The following is a description of a gene set: Genes down-regulated in CD4 T conv over-expressing: GATA1 and SATB1 versus control. from publication Fu W, Ergun A, Lu T, Hill JA, Haxhinasto S, Fassett MS, Gazit R, Adoro S, Glimcher L, Chan S, Kastner P, Rossi D, Collins JJ, Mathis D, Benoist C (PMID 22961053) The transcription factor FoxP3 partakes dominantly in the specification and function of FoxP3+ CD4+ T regulatory cells (Tregs), but is neither strictly necessary nor sufficient to determine the characteristic Treg transcriptional signature. Computational network inference and experimental testing assessed the contribution of several other transcription factors (TFs). Enforced expression of Helios or Xbp1 elicited specific signatures, but Eos, Irf4, Satb1, Lef1 and Gata1 elicited exactly the same outcome, synergizing with FoxP3 to activate most of the Treg signature, including key TFs, and enhancing FoxP3 occupancy at its genomic targets. Conversely, the Treg signature was robust to inactivation of any single cofactor. A redundant genetic switch thus locks-in the Treg phenotype, a model which accounts for several aspects of Treg physiology, differentiation and stability. Human Gene Set: GSE40277_GATA1_AND_SATB1_TRANSDUCED_VS_CTRL_CD4_TCELL_DN species: Homo sapiens, and this is the list of marker genes: DDX60, SOX4, RASA2, KLHL4, ARHGAP20, NICN1, FMNL3, ACADM, DAPK1, CHKA, RNF145, RASA3, ABL1, ANAPC4, NT5DC3, CD72, TTYH3, IFITM3, CAMK2N1, FABP5, TRIM25, DNAAF9, RASL11B, NUDT12, SFMBT2, GPRC5B, IRAG2, ARHGAP24, NOTCH3, HDAC1, IRF7, SRSF12, KCTD6, MFSD4A, GSE1, ZMYM3, SERINC5, MBNL3, SLC22A2, TTC3, SMAD7, KIT, GEMIN5, CNOT7, SPATS2, IFT172, BCAS1, ZBTB34, CYBRD1, SLC35D3, KIAA0586, ADAMTS6, UBQLN4, ATXN2, DGKD, KCNH2, MAPK7, BCL9, LETM2, SPSB1, CCR7, MCCC1, ABCD3, ENO2, TMEM120B, STAT5B, HECTD2, BCL3, HMGN3, ZMYM4, RAB3IP, TUBB2B, FRAT2, ZNF219, MEX3A, PLSCR3, ZNF451, RAG1, CRY2, TUBB, MSL1, SATB1, CACNB3, TRAK2, ARMCX1, DZIP3, CA8, ACTN1, CELSR2, ETS2, VAV2, MAP4K3, IPO9, NRP2, SLC43A1 (solute carrier family 43 member 1), MEOX1, PACSIN1, SLC7A6, CELF5, THOC7, CUX1, GTDC1, PLA2G4F, PKDCC, PLCXD2, AP1M2, NCF1, GSAP, CCR9, ST8SIA1, C14orf28, COLQ, DHX58, OASL, B4GALT3, GTF2I, RNF157, DZIP1, PMEPA1, NR4A3, LARP4, CCNJ, DGAT2, ANKRD46, WDR59, FIBCD1, C1QL3, GREB1, DDR1, PABIR1, ZFTA, SENP6, ATP11A, MCUB, ZCCHC12, ZZZ3, PKP4, DYNC2H1, POGZ, PIK3R3, TP53BP1 (NCBI Gene Id 7158), VEGFA, PTDSS2 (phosphatidylserine synthase 2), ZDHHC15 (NCBI Gene Id 158866), DCAF17, B3GLCT, CTSK, FOSL2, POGK, TUBB2A, EPB41L2, IRS2, CNFN, IFI44, EIF4G2, TIA1, SALL2, HOOK1 (hook microtubule tethering protein 1), CCNJL, CATSPERD, RAI1, MEF2A, ADCY6, ID1, SWAP70, MACO1 (NCBI Gene Id 55219), BASP1, STK26, PIP4K2A, SECTM1, TBC1D4, MAP4K4, KTN1, PHC1, TRRAP, SKI, SMOX, SLC3A1, CMYA5, SLC25A38, TCF7L2, NT5M, DNAH8, C5, XPO6, ABCG2, AGTPBP1, TBC1D19, SNX18, EHMT1, CHRNB1, SLC22A17, GPSM1, TNNT2, AHCYL2, IFIT1B, ITK, CTIF, BAZ2B